The following is a description of a gene set: studied in species Homo sapiens Clinodactyly of the 3rd finger Human Gene Set: HP_CLINODACTYLY_OF_THE_3RD_FINGER, and this is the list of marker genes: MEG3, KNSTRN (kinetochore localized astrin (SPAG5) binding protein), ERI1, PKDCC, DLK1, PIK3CD, RTL1